The following is a description of a gene set: Genes up-regulated in resting CD4 T cells: healthy versus systemic lupus erythrematosus (SLE). from publication Fernandez DR, Telarico T, Bonilla E, Li Q, Banerjee S, Middleton FA, Phillips PE, Crow MK, Oess S, Muller-Esterl W, Perl A (PMID 19201859) Human Gene Set: GSE13887_HEALTHY_VS_LUPUS_RESTING_CD4_TCELL_UP CD3-positive T cells were negatively isolated from 10 SLE patients and 9 healthy controls without SLE. All of the SLE samples and control samples were compared with one another to identify baseline differences in expression due to the disease. Next, T cell preparations from 4 of the control subjects were stimulated with either Nitric Oxide (NOC-18) 600 uM for 24hr or stimulated through CD3/CD28 for 24hr to determine which genes were responsive to these signaling mechanisms. Here, we show that activity of the mammalian target of rapamycin (mTOR), which is a sensor of the mitochondrial transmembrane potential, is increased in SLE T cells. Activation of mTOR was inducible by NO, a key trigger of MHP which in turn enhanced the expression of HRES-1/Rab4, a small GTPase that regulates recycling of surface receptors through early endosomes. Expression of HRES-1/Rab4 was increased in SLE T cells and, in accordance with its dominant impact on the endocytic recycling of CD4, it was inversely correlated with diminished CD4 expression. HRES-1/Rab4 over-expression was also inversely correlated with diminished TCRζ protein levels. Combined with follow up studies, these results suggest that activation of mTOR causes the loss of TCRζ in lupus T cells through HRES-1/Rab4-dependent lysosomal degradation. studied in species Homo sapiens, and this is the list of marker genes: POM121L2, MFSD2B, QPRT, MON1A (NCBI Gene Id 84315), ADGRF5, EML1, MMD, RPRD1B, ADGRL2, CENPC, ANKS1A, AP3S1, ZDHHC9, PARP3, MRGPRF, PRR14, UBL7, FAM170A, MGRN1, MT-ND2, TPM1, RFPL4A, IRX5, PADI3, TUBB4A, MB, ITGA5, S100A16, GPR143, ADGRF2P, CCL3, KRT6B (keratin 6B), XDH, NAPB, FECH, FIGLA, BDKRB2, SFXN5, TSHZ2 (teashirt zinc finger homeobox 2), CXCL12, KLF2, NIPSNAP3A, S100A14, ARRDC5, MRPL30, ABRA, TMIE, CXCR2, APP, DDO (NCBI Gene Id 8528), MAN1B1, CAPZB, LRRC27, ATXN2L, MEP1B, UBXN11, CES5A, EXT1, WDTC1, CRHBP, POU2F3, LAMA3, TPO, ETF1, TMEM74, CD5, MPHOSPH10, PRAF2, FOXJ2 (forkhead box J2), MGAT2, CUEDC1, CHAD, LAMP1, GRXCR1, F8, KRT5, SLC2A10, GM2A, NECAB1, GPR141, RIPK4, OLIG2, PNMA2, PADI4, CDYL2, ARL16, NR2E3 (nuclear receptor subfamily 2 group E member 3), PARD6G, RNF215, MARCKS, MAOA, NXPE1, MAP3K9, CYRIB, ORM1, STRBP, FBXO10, AQP11 (NCBI Gene Id 282679), SOSTDC1, RPL19, PSPH, AREG, FLOT2, SNX1, CPNE8, PANX3, RBMY1A1, COQ8B, TMEM45A, GZMM, PNPLA1, ENO3, LILRB3, IDH1, TRO, UBD